The following is a description of a gene set: studied in species Homo sapiens Normally functioning lecithin retinol acyltransferase (LRAT) mediates the transfer of an acyl group onto all-trans-retinol (atROL), forming retinyl esters (REs), the storage form of retinoids. Defects in LRAT cause Leber congenital amaurosis type 14 (LCA14, MIM:613341), an autosomal recessive juvenile-onset retinal dystrophy affecting rod and cone photoreceptors. Leber congenital amaurosis (LCA) comprises a group of early-onset retinal dystrophies characterized by vision loss, nystagmus, and severe retinal dysfunction (Chung & Traboulsi 2009). part of: Retinoid cycle disease events Reactome Pathway: Defective visual phototransduction due to LRAT loss of function, and this is the list of marker genes: RBP1, LRAT